Given this list of marker genes USP15, BIRC3, ZCCHC3, PUM2, DHX58, PUM1, NLRX1, ZC3HAV1, UFD1, ANKRD17, HDAC6, NOP53, GPATCH3, BIRC2, NPLOC4, DDX60, USP17L2, TRIM15, C1QBP, SEC14L1, OASL, RNF125, here is a description of the gene set: Human Gene Set: GOBP_REGULATION_OF_RIG_I_SIGNALING_PATHWAY Any process that modulates the frequency, rate or extent of the RIG-I signaling pathway. species: Homo sapiens